Given this list of marker genes Ptpn1, Gpr37l1, Gsk3a, Nos3, Klk1b5, Or51e2, Ttr, Oxtr, Plcb3 (phospholipase C, beta 3, NCBI Gene Id 18797), Nedd4l, Klk1b24, Tac1, Manf, Nr3c2, Ece1, Adm, Sod2, Klk1b11 (NCBI Gene Id 16613), Edn2, Klk1b9, Avp, Prep, Ace, Avpr1a, Klk1b1, Rarres2, Edn3, Uts2r, Avpr1b, Agt, Serpinf2, Mme, Rasl10b, Mas1, Camk2n1, F2r, Apln, Adrb2, Edn1, Smtn (NCBI Gene Id 29856), Adra1b, Adora1, Drd3, Slc2a5, Klk1b22, Nox1, Bmpr2, Crh, Klk1b4, Eng, Drd2, Rhoa, Ncald, Kcnk3 (potassium channel, subfamily K, member 3), Klk1b27, Rnls (renalase, FAD-dependent amine oxidase), Cyba, Klk1b3, Kcnk6, Ier3, Avpr2, Pdgfb, F2rl1, Nav2, Tac4, Klk1b21, Nppa, Mcpt4, Kl, Nr2f2, Atp6ap2, Kcnn4, Agtr1a, Ntsr1, Slc4a5, Calca, Bbs4, Enpep, Corin, Tnni3, Ednrb, Adrb1, Chrm3, Adra1a, Klk1, Klk1b26, Nkx2-1 (NCBI Gene Id 21869), Mrgprd (NCBI Gene Id 211578), Ace2, Wnk1 (WNK lysine deficient protein kinase 1), Nmu, Uts2, Cpa3, Ahr, Ar, Cyp2j5, Coro2b, Gja1, Nppb, Asic2, Agtr1b, Chrna7, Tacr1, Hsd11b2, Kdr, Adra1d, Spx, G6pdx (NCBI Gene Id 14381), Adrb3, Agtr2 (NCBI Gene Id 11609), Klk1b8, Ddah1, Cyp11b2, Fshr (NCBI Gene Id 14309), Adm2, Ace3, Gja5, Gas6, Rps6ka2, Mecp2, Trpv1, Ndst2, Postn, Ren1, Sucnr1, P2rx2, Ptpro, Anpep, Prcp, Tnf, Drd5, Adamts16, Emp2 (epithelial membrane protein 2), Tpm1 (NCBI Gene Id 97508), Comt, Arhgap42, Klk1b16, here is a description of the gene set: studied in species Mus musculus The process that modulates the force with which blood travels through the systemic arterial circulatory system. The process is controlled by a balance of processes that increase pressure and decrease pressure. Mouse Gene Set: GOBP_REGULATION_OF_SYSTEMIC_ARTERIAL_BLOOD_PRESSURE